The following is a description of a gene set: from publication Schaefer CF, Anthony K, Krupa S, Buchoff J, Day M, Hannay T, Buetow KH (PMID 18832364) Wnt signaling network studied in species Homo sapiens Human Gene Set: PID_WNT_SIGNALING_PATHWAY, and this is the list of marker genes: FZD5, KREMEN1, DKK1, WNT3A, FZD4, FZD2, IGFBP4, WNT7A, FZD6, LRP6, ATP6AP2, ROR2, CTHRC1, KREMEN2, FZD9, FZD7, FZD10, WNT3 (Wnt family member 3), WNT2, WNT1, RSPO1, RYK, LRP5, WNT5A, FZD1, FZD8, WIF1, WNT7B